The following is a description of a gene set: Genes up-regulated in comparison of untreated macrophages versus those cultured with M-CSF and Pam3Cys (TLR2 agonist). Gene expression analysis of freshly isolated CD14+ human monocytes and monocytes cultured in the presence or absence of interferon (IFN) -gamma for 24 h and then stimulated with Pam3Cys, a Toll-like receptor (TLR) 2 ligand, for 6 h. Results provide insight into mechanisms by which IFN-gamma reprograms early macrophage differentiation and subsequent response to TLR ligands. Human Gene Set: GSE11864_UNTREATED_VS_CSF1_PAM3CYS_IN_MAC_UP from publication Hu X, Chung AY, Wu I, Foldi J, Chen J, Ji JD, Tateya T, Kang YJ, Han J, Gessler M, Kageyama R, Ivashkiv LB (PMID 18976936) studied in species Homo sapiens, and this is the list of marker genes: NXPE3, ABHD2, RASGEF1A, MAP3K2, TMC4, CLIP4, HPS3 (HPS3 biogenesis of lysosomal organelles complex 2 subunit 1), NAA80, PHF21A, KANSL2, LINC01127, LINC00877, ID3, SEC24B, TAFAZZIN, IKZF5, BCAS3, TMEM106B, RELL2, NFATC2IP, CRBN, TAF9B, EDEM2, R3HDM1, GNG7, SPATA13, ST6GAL1, MFSD14CP, GMFG, MPC1 (NCBI Gene Id 51660), MPP1, DOP1A, C2orf69, UICLM, PPP1R2, OMA1, ERCC5, OXCT1, F11-AS1, PARP16, MSH3, UNC93B1, NUDT16L2P, SMIM14, NTNG2, PEX19, SORD, HSPBAP1, CWC25, RTF1, RANBP6, ELF5, PHKA2, DECR1, LIMD2, IL12A, BRD2, SEPTIN7, ZYX, ALKBH5, MTMR1, SULF2, RFXAP, TGOLN2, NUP214, THOC5, COTL1, HNRNPDL, PCSK7, SP140, ZXDB, MICU1, AFF1, MEF2D, CXXC5, RCBTB2, FKBP1A, AGO4, PLAAT4, BNIP3L, DDIT4, NLRP12, SCARB2, SSH2, SH2B2, BCR, LIN7B, AIFM3, SLC10A3, CCNC, TBRG1 (transforming growth factor beta regulator 1), TP53INP1, JAZF1, GNAI2, LPCAT4, SLC15A2, INTS10, RNF168, PHF19, PKP2, VHL, KLF3, ACRBP, ZC3H7A, PTPN4, RBMS1, CD79B, SETD2, TEX2, SH3BGRL, CPVL, SLC22A4, ACSS1, TOB2, TNNT1, THEM6, REEP4, SAMD4B, RSL24D1, LEPR, DUS2, TSPYL4, CFL2, C1RL, BRD3OS, UBA7, BRAF, SNX20, MINDY1, SYT11, GRK6, ZNF669, STXBP3, RPS6, MIDEAS, ZBTB43, ZBED10P, FAM76B, EIF3LP3, PNOC, POC1B, ZRSR2, ZNF395, ERBB4, SLC46A3, MDH2, PPIL3, ZNF451, NR1D2, LONRF3, SCO2, VPS26C, FAM13A-AS1, MAGED1, SLC25A5, CRLF3, CNOT7, PGM2, RNF217, ISCA1, RAP1A, BCLAF1, MNT, UBE2D1, NSA2, USP39, AP2A1, HIRA, NET1, P4HTM (NCBI Gene Id 54681), PHB2, ARRB2 (arrestin beta 2), CEP152, CTSC, PDCD6P1, IFFO2, PSRC1, CD300A, FLT3 (fms related receptor tyrosine kinase 3), SRSF3, CDK13, BAG2, CACNA2D4, AP3S2, SLC46A2, MIEF1 (mitochondrial elongation factor 1), GAB2, RAB24, VCL, CCP110, MTHFR, SENCR, SGSM2, SLTM, RPGRIP1, TMC6, TCN2 (transcobalamin 2)